The following is a description of a gene set: from publication Macagno A, Molteni M, Rinaldi A, Bertoni F, Lanzavecchia A, Rossetti C, Sallusto F (PMID 16717116) Genes down-regulated in monocyte-derived dendritic cells: LPS like antigen from O. planktothrix (3h) versus LPS and LPS like antigen from O. planktothrix (3h). Human Gene Set: GSE4748_CYANOBACTERIUM_LPSLIKE_VS_LPS_AND_CYANOBACTERIUM_LPSLIKE_STIM_DC_3H_DN studied in species Homo sapiens A cyanobacterial LPS antagonist prevents endotoxin shock and blocks sustained TLR4 stimulation required for cytokine expression. We report the identification and biologic characterization of an LPS-like molecule extracted from the cyanobacterium Oscillatoria Planktothrix FP1 (CyP)., and this is the list of marker genes: NCF4, KCNH3, ODAD4, TUBB4B, SRPK1, HERC3, ENSG00000204684, ELOF1, ELANE, NIPAL1, LINC00343, LRRC4, UBAP1, HACD4, CAVIN4, CAMP, PYGL, GABRR2, FKBP1A, H1-6, USP49, VPS9D1, AKIRIN2, ARRB2, TLCD4, MARK3, SH3GLB1, PCOLCE2, PRTN3, LTBR, CCDC26, MS4A8, MAF1, SRRD, C6orf163, H2AJ, STYK1, AIF1, TUBA4A, IRX4, CREB5, UBTD1, AP3B2, OR5AK4P, LINC02243, PLEK2, BST1, ADCY4, OMG, AATK, YPEL4, FGFBP1, OSBP2, IGF2BP2, COX4I2, SHKBP1, FOXO3, ZFP36, BTNL8, RNASE3, SDR9C7, OLFM4, CLSTN2, SLPI, TUBB2A, RBM38, INHBA, INHBB, SLC1A5, GPR146, SPACDR, ENSG00000284948, LCN2, MXD3, CEACAM6, PNRC1, MROCKI, CEACAM8, KLF1, LPL, RAB13, MAPK3, OLIG3, MAFG, INSC, TCN1, TAS2R1, FAM200B, GJB6, OR2W3, MAGEA4, S100A11, ECHDC3, KDM7A-DT, PSG7, SULT1B1, TUBB3, CYSTM1, CLEC7A, TAAR8, DLGAP1-AS2, S100A3, BEND7, BBOF1, RNF19B, THBS3 (NCBI Gene Id 7059), KRTAP11-1, PICK1, SBNO2, DLGAP1-AS3, SEMA4A, CRISP3, STC1, PDLIM7 (PDZ and LIM domain 7), ANXA3, LINC00664, TSBP1, MIR21, BASP1, DGKH, RETN, WFDC11, SLC22A4, WDR26 (WD repeat domain 26), ANK1, TRIM67, DYSF, SHROOM2, LTF, UGT1A6, CREG1, TRAK2, RASGRP4, MAG, DOK3, TMEM132B, ZDHHC19, CAPN6, RALYL, RNF24, LILRB3, VSNL1, HSD11B1, SYTL4, TERB1, PLBD1, SFRP2, SLC22A24, RANBP10, BPI, MMP25, KCNJ2, PGM5, NPL, CCDC197, FKBP5, ZNF687, MMP9, WDFY3-AS2, SRXN1, AZU1, SOWAHA, PGLYRP1, GFOD2, NPTX1, SNHG28, FCGR3B, VASP, MMP8, RBPJ, RNASE2, ARL4A, NFIB, CHURC1, IL1RN, FOXI1, PTK2B, CDC42EP3, PLPPR2, NATD1, SIRPB1, DEFA4, S100A9, TLR5, CLDN17, MAPK11, MAB21L3, LINC01538, MBNL1-AS1, IGFL2, GABRR1, ERG, ASIC5, RUFY2